Given this list of marker genes KMT2D, G6PD, FOXE1, GATA1, PAX8, TSHR, SLC30A10, KLF1, UROS (NCBI Gene Id 7390), NKX2-1, PIGA, FARSB, HBB, CASK, UGT1A1, NKX2-5, PKLR, SLC10A1, SLC26A4, RHAG, NHLRC2 (NCBI Gene Id 54835), here is a description of the gene set: Unconjugated hyperbilirubinemia An increased amount of unconjugated (indirect) bilurubin in the blood. Human Gene Set: HP_UNCONJUGATED_HYPERBILIRUBINEMIA studied in species Homo sapiens